Given this list of marker genes TBCK, MYCBP, DNAJA3, EXO5, FAM216A, GSPT2, ZNF443, PRIMPOL, SPTY2D1, DHX33, COX14, TLR1, TIMM8A, MSTO1, IL21R, DDX23, ZNF302, MRPL12, VPS33B, RBL1, RAD51C, RPAP2, TBC1D14, MSH2, SNRPA1, MOAP1, C15orf61, ERC2, TLR6, TARBP2, NIFK-AS1, CSE1L, MRPS31, RNF4, URB1, TRIM49, NUDT6, ELK3, TSHZ1, DZIP3, EBPL, GXYLT1, POP1, CAD (carbamoyl-phosphate synthetase 2, aspartate transcarbamylase, and dihydroorotase), SUPT3H, SFR1, MAGOHB, B3GALNT1, CDC23, INTS4, MRPS26, KBTBD7, HHEX, NME6, PALB2, TPMT, EDC3, ATPSCKMT (ATP synthase c subunit lysine N-methyltransferase), IFT27, ISCA2, YLPM1, IRAG2, INTS8, MBLAC2, PIGF, COG2, IPO11, IRF2BP2, PHF14, LBHD1, TNRC18, P2RY13, KIAA0586, COA4, PDE6D, FLAD1, SEPHS2, RMI1, FAM78A, MRPL36, TRUB1, MTFR2, RTN4IP1, ZSCAN29, MTRES1, DUS2, GET1, ZNF561, GGCT (gamma-glutamylcyclotransferase), RELL2, MRPS25, RCN2, RALBP1, SWSAP1, ZNF544, TRMT12, THNSL1, UBR7, POLR1G, THOC5, DCP1B, ARHGEF28, LINC02243 (long intergenic non-protein coding RNA 2243), ANP32A, PDCD7, NDUFA5, TTI2, GIMAP1, TRMT13, MTFR1L, PSMG4, TP53RK, METTL3, ZCCHC24, SIMC1P1, TMEM120A, RPP40, ABHD15, METTL21A, GAR1, HMG20A, SEC13, EIF2B1, MGME1, ZNF557, TAF4, RAD52, SLC25A11, WDR3, ARV1, CYB561A3, NFIA, ATPAF2, TRIAP1, CYREN, INPP4A, ZNF559, TIMM21, SLC35C2 (solute carrier family 35 member C2), LETR1, DNAAF2, AGGF1, CCDC51, PAAF1, SYT8, TBL2, MAP7, TRMT10A, FAM98B, RELL1, CETN3, PRIM1, TSPYL5, STAM2, ZNF229, DEF8 (NCBI Gene Id 54849), POP5, RPUSD2, KAT14, SIKE1, DDIAS, PDCD4, MCEE, HEATR6, LARP4, RANGRF, ALKBH2, FAHD1, PET100, WDR53, ISY1, FZD10-AS1, SUOX, RANBP6, RCSD1, SDK2, TRIM27, NDUFB1, FLI1, NAIF1, CCT4, CCNC, GIT2, TFB2M, PUS1, AIRIM, URB2, FBXL4, FANCF, SLC25A39, CMTM4, TBCC, EIF2B2, ESRRA, DFFA, SRPK1, FOS, CENPU, CRLS1, here is a description of the gene set: Genes up-regulated in comparison of control conventional dendritic cells (cDC) at 0 h versus cDCs infected with Newcastle disease virus (NDV) at 4 h. species: Homo sapiens from publication Zaslavsky E, Hershberg U, Seto J, Pham AM, Marquez S, Duke JL, Wetmur JG, Tenoever BR, Sealfon SC, Kleinstein SH (PMID 20164420) Human Gene Set: GSE18791_CTRL_VS_NEWCASTLE_VIRUS_DC_4H_UP The dendritic cell (DC) is a master regulator of immune responses. Pathogenic viruses subvert normal immune function in DCs through the expression of immune antagonists. Understanding how these antagonists interact with the host immune system requires knowledge of the underlying genetic regulatory network that operates during an uninhibited antiviral response. In order to isolate and identify this network, we studied DCs infected with Newcastle Disease Virus (NDV), which is able to stimulate innate immunity and DC maturation through activation of RIG-I signaling, but lacks the ability to evade the human interferon response. To analyze this experimental model, we developed a new approach integrating genome-wide expression kinetics and time-dependent promoter analysis. We found that the genetic program underlying the antiviral cell state transition during the first 18-hours post-infection could be explained by a single regulatory network. Gene expression changes were driven by a step-wise multi-factor cascading control mechanism, where the specific transcription factors controlling expression changed over time. Within this network, most individual genes are regulated by multiple factors, indicating robustness against virus-encoded immune evasion genes. In addition to effectively recapitulating current biological knowledge, we predicted, and validated experimentally, antiviral roles for several novel transcription factors. More generally, our results show how a genetic program can be temporally controlled through a single regulatory network to achieve the large-scale genetic reprogramming characteristic of cell state transitions.